The following is a description of a gene set: We characterized differential gene expression profiles of fibroblast cell lines harboring single or double-homozygous null mutations in H-ras and N-ras. Whereas the expression level of the individual H-, N- and K-ras genes appeared unaffected by the presence or absence of the other ras loci, significant differences were observed between the expression profiles of cells missing N-ras and/or H-ras. Absence of N-ras produced much stronger effects than absence of H-ras over the profile of the cellular transcriptome. N-ras(-/-) and H-ras(-/-) fibroblasts displayed rather antagonistic expression profiles and the transcriptome of H-ras(-/-) cells was significantly closer to that of wild-type fibroblasts than to that of N-ras(-/-) cells. Classifying all differentially expressed genes into functional categories suggested specific roles for H-Ras and N-Ras. It was particularly striking in N-ras(-/-) cells the upregulation of a remarkable number of immunity-related genes, as well as of several loci involved in apoptosis. Reverse-phase protein array assays demonstrated in the same N-ras(-/-) cells the overexpression and nuclear migration of tyrosine phosphorylated signal transducer and activator of transcription 1 (Stat1) which was concomitant with transcriptional activation mediated by interferon-stimulated response elements. Significantly enhanced numbers of apoptotic cells were also detected in cultures of N-ras(-/-) cells. Our data support the notion that different Ras isoforms play functionally distinct cellular roles and indicate that N-Ras is significantly involved in immune modulation/host defense and apoptotic responses. species: Mus musculus Mouse Gene Set: CASTELLANO_NRAS_TARGETS_DN Genes down-regulated in MEF cells (embryonic fibroblast) isolated from NRAS knockout mice. from publication Castellano E, De Las Rivas J, Guerrero C, Santos E (PMID 16909116), and this is the list of marker genes: Nras, Limk1, Ncam1, Rps6ka2, Cdkn2a (NCBI Gene Id 18560), Rbm38, Akap12, Rbpms (RNA binding protein gene with multiple splicing), Htra1, Ankrd1, Fbln2, Pkia (NCBI Gene Id 99614), Zftraf1, Plekho1